The following is a description of a gene set: from publication Yevshin I, Sharipov R, Kolmykov S, Kondrakhin Y, Kolpakov F (PMID 30445619) Mouse Gene Set: CTR9_TARGET_GENES studied in species Mus musculus Genes containing one or more binding sites for (Ctr9) in their promoter regions (TSS -1000,+100 bp) as identified by GTRD version 20.06 ChIP-seq harmonization., and this is the list of marker genes: Mfsd11, Gm25296, Rps19, Ewsr1, Necab3, Elf1, Gm11520, Rpl11, Cacnb3, Zfp322a, Ncapd2, Fgfr1op2, Napepld, Sox12, Mir6236, Mcm10, Itga6, Unk, Mir207, Septin2, Gm4890, Smarcd1, 3010003L21Rik, Lrrc24, Lrrc2, Hdac1, Cc2d1a, Wdtc1, AV099323, L1td1, Mrpl12, Ssmem1, Kin (NCBI Gene Id 209375), Srsf11, Ccnb2, Rab10os, Pnrc2, Hax1, mt-Tl2, Prc1, Shisa7, 1700001G11Rik, Mtg1, Taok3, Trex1, Smg7 (SMG7 nonsense mediated mRNA decay factor), Actb, Lactb2, Adipor2, Cdh24, Dbnl, Ubap2, Ftl1, Iqcg, Ash1l, 1110002L01Rik, Gm15441, Actg1, Rps11 (NCBI Gene Id 27207), Trim65, Vgf, Morc3, Stx5a, Tsg101, Oma1, Sppl2a, Btbd9, Gm25855, Mir290a, Ctnna3, Mfsd14a (NCBI Gene Id 15247), Slc17a9, Pnrc1, Gtpbp6, Etfrf1, 2410002F23Rik, Tor1aip2, Rps15, Cyb5r1, Ccdc47, Apc2, Zzef1, Gm10080, Mir7067 (NCBI Gene Id 102465984), Rps18, Vrk3, Mgme1, Cyb5d1, Atf1, Ddias, Ankrd60, Snx14, Tmem38a, Acin1, Ube2q1, Jarid2, mt-Tl1, Rbm4b, Cyb5r3, Otx2, Rgl2, Purb, Serhl, Hsp90ab1, Rnf44, Dnaja1, Commd1, Rpl18, Gm14143, H3c15, Tdrd3, Isca1, Fbxo27, Dvl2, Ubb, Pip4k2b, Kat8 (NCBI Gene Id 76692), Tmco1, H4c3, Rnft1 (ring finger protein, transmembrane 1), 1110038B12Rik, Ankrd2, Rbm4, Timm13, Ctxn1, Dnajb4, Arhgap27, Stmn1, Nxf1, Gm22711, Dpysl5, Srsf10, Nop58, Sgf29, Kank2, Fam227b, Praf2, Klf10 (Kruppel-like transcription factor 10), Rcor2, Dph7, Selenok, Gstcd, Bbs1, Gm38058, Diaph1, Hdlbp, Ccdc97, Mir291a, Mcts2, Phc1, Mir294, Trim41, Lbr, Tgif2 (TGFB-induced factor homeobox 2), Tdg, Slc2a1, 4930519P11Rik, Pkp4, Tmem168, Pdrg1, H2bc21, Ppig, Naa60, Fbxo5, Cdk12, Dph3, Ranbp1, Eci1, Tbc1d17, Ralgps2, Cep95, Gm15564, Mir292b, Nfyb, Naa10, Washc1, Chaserr, Mus81, Hdhd3, Gm16892, Setd5, Zfr2, Luc7l3, Gm12984 (NCBI Gene Id 102632547), Rbm7, Zpbp, Baz2b, Rbpj, Pde4dip, Gm16069, Pnma1, Ttc36, Usp21, Gtpbp10, Fcer1g, Pate2, Ddx42, Rab27a, Wdr62, Snord45c, Oxct1, Kctd15, Mir295, Trmt1, Gm24916, Dppa5a, Npat, Apc, Trip12, Zfp82, Fbxl17, Zfp292, mt-Nd1, Edc4, Mindy1, Gm22748, Fam83e, Plod3, Ube4b, Rabgap1, Gpaa1, H2bc15, Snora57, Orc5, Hnrnpk, Wnk4, Gm16283, Inpp5e (NCBI Gene Id 64436), Snord43, Gm22980, Rtkn2 (rhotekin 2, NCBI Gene Id 631847), Oxnad1, Fgfr3-ps, Rprd2, Rpl10a, Bbs10, 1600020E01Rik, Tstd1, Mmaa, Ppm1f, Sgo1, Efhc1, Gm15270, Ppp1cc, Snhg3, Fdft1, mt-Nd5, Mef2b, Larp4, Pop5 (processing of precursor 5, ribonuclease P/MRP family (S. cerevisiae)), Vps33a, Ndufc2, Rpp21, Eml3, Rhbdl1, Zfp219, H2ac15, Arrdc3, H2ac12 (NCBI Gene Id 319168), Erlin1, Hdac4, Polg2, 0610010K14Rik, Gm26511, Iah1, Znfx1, Maml1, Ccdc88a, Nubp1, Gm13267, Fbxo46, Ldha, Inpp5k, Gramd2a, Sinhcaf, Cdca2, Ptp4a2, Sh3d21, Ccser2, Rpl26, H4c18, Prkag1, Cetn3, Eif1, Cyct, Plpp5, Zbtb45, Gm26202, Leprot, Pacs1, Atf7ip, Tbc1d23, Ppp6r1, Rhof, Trp53inp1, Gm26387, Agfg1, Unc13d, Nudt16l1, Taf1d, Cop1, Map1lc3b, Cul4a, Enah, 1700058P15Rik (RIKEN cDNA 1700058P15 gene), Cfap53, Nras, Tor1a, Fam209 (family with sequence similarity 209), Epn1, Gm15510, Snora24, Usf2, Psmg1, Orai3, Hnrnpm, Snora65, Kif15, Snord55, Ncl, Mbd3, Zfp696, Copg1, H4c9, Capzb, Prps1l3, Zscan22, Ticam1, Kank3, Diablo, Pygo2, Mrpl51, Dcaf8, Rabggtb, Pcna (NCBI Gene Id 18538), Akr1a1, Zfp646, Jade3, Rpl15 (NCBI Gene Id 66480), 1700088E04Rik, Sp3, Asb3, Crebzf, Slc27a3, Pisd, Ino80, Raver1, Kpna2, Tbk1, Erlec1, Mir431, Eif4a2, Josd2, Golga1, Arih1, Gm12758, Impdh2, Cd2ap, Gm12516, Ctnnal1, Ing2, H2bc12, Smg6, Arhgef1, Med22, Cfap251, Topors, Mir290b, Gpx1, Oxct1as, Schip1, Rex1bd, Ipo5, Lrrc28, Zbtb37, Wdr5b, mt-Ts2, Dip2b, Lefty2, Rsad1, 1110019D14Rik, Trim46, Tigd3, Grhpr, Uba2, Bphl, Nucks1, Rpl34, Capn15 (calpain 15), Gm5113, Thoc6, Rubcn, Usp6nl, Rusc1 (NCBI Gene Id 99477), Pgam5, Rnf151, Rhbdd3, Lrif1, Dlc1, Stip1, Mir7655, Mtf2, Cox20, Trim37, Rpl7, Pcyt2, Tssk6, Rps29, Cox7a1, Zglp1, Tmem201, Srcap, Gm25744, Sipa1l1, Ttll4, Dcp2, Kdm4c, Akt1s1, Ash2l, Plpp1, Gm31266, Gm12762, Chd2, Cenph, Zfp518a, Fubp1 (NCBI Gene Id 77392), Usp10, Hdhd2, Klf6, Lpcat3, Rilp, 4632404H12Rik, Ift74, Snhg9, Senp3, Naa35, Eogt, Mat2b, AW209491, Fam193a, Mettl25b, 2200002D01Rik, Ube2w, Rnf4, 1700023H06Rik (RIKEN cDNA 1700023H06 gene), Lasp1, Gm24044, Ncoa4, Nat10, Snora61, Fyttd1, Zfp329, Spag1, Mir101b, Rbm15b, Gm11398, Bola1, Cfap69, Itfg2, Nudt9, Slc38a1, Polr2f, Dtwd2, Prpf4b, Sec61a2, Amigo3, Ccdc59, Hsd17b8, 0610009L18Rik, Bcar3, Cd320, Sanbr, Tti2, Cirbp, Sra1, Elk4, Jade1, Gfpt1, Rpl36a, Ska2, Lck, Atxn2l, Zfp619, Hmmr, Abitram, Lnpep, Tmem270, Cnih4, Lzic, Ovca2, Gm19710, Gm12267, Ppp1r18, Snora64, Tom1, Mir8120, Kctd5, Zfp81, Ppp2r3d, Cox16, Rcc1, Pcnp, Itpr3, Gm12059, Gm21985, Kat7, Mbtps2, Egln2, Atp5f1d, Med17 (mediator complex subunit 17), Zfp653, Soat1, Gm26604, Hsf5, Lypla1, Uckl1os, Gm23246, Tuba1b, Pole4, Ssc4d, Zdhhc20, Rars1, Msh4, Zfp668, Tfg, Ccdc163, H4c8, Rpl5, Tmpo, Cldn7, Gmip, Tob2, 1810030O07Rik, Aftph, Cdkl3, Rab26, Mterf2, Mxd1, Dcdc2b, Gm24452, Wbp2 (WW domain binding protein 2), 4930544D05Rik, Stap2, Mir8092, Mrpl41, Gm23212, Zic5, Tbc1d8, Hnrnpu, Cox18, Ager, Psip1, Slc1a5, Mcm7, 4930481B07Rik (RIKEN cDNA 4930481B07 gene), Yy2, Pcmt1, Slc35c2 (solute carrier family 35, member C2), Ccdc157, Bcas2, Arih2, Dnai7, Rad51, H2af-ps2, Gnb2, Rnpc3, Zfp866, Snx9, Fbxo22, Klf3, Rnf13, H3c2, Spmip11, Arf1, Plppr2, Epha2, Gas5, Atp5f1c, Nit2, Tapbp, Myo10, Gm22680, H2ac20, Plscr3, Ccnd3-ps, Taf6l, Rbm3os, Slc16a3, H2ac14-ps, Snord22, Zfp799, Ap4m1, Sart3, Timmdc1, Slc31a1, Pdcd6, Tmem106a, Ipmk, Mkrn1, Ube2k, Myl6b, Cdk7, Disp2, Arf4, Rmi1, Timm29, Snord45b, Map3k1, Ksr2, Klhl13, Prrt2 (proline-rich transmembrane protein 2), Clta, Rpl3, Mmadhc, Huwe1, Cspp1, Anp32e, Slc12a6, Stx3, Gm17259, E130102H24Rik, Tpd52, Txnip, Snx5, Mcm6, Twf1, Afmid, Arid1a, Itgb1bp1, Snhg5, H1f3, Kat2a (K(lysine) acetyltransferase 2A), Taf11, Trim6 (tripartite motif-containing 6), mt-Th, Baiap2l2, Atp2b1, Rplp0, Gm6069, Gm23201, Mir291b, Lmf2, Stam, Gm23969, Dyrk1b, Mir3071, Mtmr4, Anks3, A230072E10Rik, Lysmd3, Znhit2, Slc25a36, Caprin2, Uap1l1, Dcps, Fam174c, Wwp2, Cort, Wdr81, Grhl2, Mir1949, Gm22455, Reep2, Cmya5, Xpot, Eif4a1, Zfp346, Gm26590, Gm10785, 2700078F05Rik, Lhfpl5, Arhgap35, Isy1, Tbrg1, Ifi30, Gm23946, Ssr2, Snapc3, Zfp229 (zinc finger protein 229), Ppp1r8, Ints12, Snord49a, Prx, Snhg17, Dennd2c, Zfp91 (NCBI Gene Id 67567), Gm4462, Ddah2, Tsc22d1, Tmem230, Mir292, Arsa, Mtfr2, H2ac5-ps, Dusp28 (dual specificity phosphatase 28), H3c8, Prorsd1, Rala, Slc7a7, Acsl3, Pam16, H2bc3, Bag6, Apex1, Tbc1d7, Kctd9, Mir7017, Cds2, Fmc1, Rps23rg1, Epas1, Pcid2, Usp7, N4bp2os, Epm2aip1, Pkmyt1, Jmjd8, Fbxl5, Eef1g, Kcnn2 (potassium intermediate/small conductance calcium-activated channel, subfamily N, member 2), Pggt1b, Cdo1, E4f1, Greb1l, Thoc5, Spty2d1, Pagr1a, Ddx5, Eif4g2, Adhfe1, Kmt2e, Snord87, Eif4a3, Sirt7, Cd2bp2, Srsf5, Otud1, H2bc11, Ptp4a1, Bltp3a, Ypel5, Mmp24os1, Prpf6, Gm23690, Gm10433, Meg3, Zfp788, Ube2n, Gm23301, Golph3l, Psen1, Fam151b, Pms2, Nfkbil1, Gm21182, Snora21, Mir6991, Rmc1, Csrp2, Poldip3, Man2c1, Ppcdc, Gdpd3, Hmgn2, Tex52, Ago3, Gtf2a2, Phtf1, Dnajc11, Vapa, Scrib, Dhx30, Mapkbp1, Zfp367, Pabpn1, Prr3, Ahdc1, Gm57857, Rps15a, Rbm25, Snora73b, Akap5, Snord38a, Znhit1, Akt2, Mirlet7g, Ssh3, Ndufb6, Mfsd10, Arl6ip1, Rab11b, Kbtbd4, Borcs8, Malat1, Caprin1, Zfp687, Rpl21 (ribosomal protein L21), Gabarap, Ints5, Rps8, AF357399, Fut11, Gm11175, Cand1, H2bc6, Gsto2, Gm22357, Srsf2, Gm20544, Gm19325, Tgfbr3l, Ddx41, Vegfb, Ranbp17 (RAN binding protein 17), Pold1, H4c6, Slc8a2, Utp14b, Rogdi, Gnpnat1, 1700096K18Rik, Gm23639, Gm22744, 6030443J06Rik, Spaca6, Spc25, Mettl9, Ggnbp2, Zfp74, 4930592C13Rik, Sigirr, C130036L24Rik, Cops7a, Polr2a, Ddx23, Jpt2, Zfp638, Uspl1, Klhl10, Tcf7, Clhc1, Zfp106, Phf1, Nkiras1, Dap3, Paxip1, Zfp513, Gpr19, 4931406C07Rik, Osbpl1a, Opa1, Mir5119, Dido1, 5031425E22Rik, Rbm47, Ddx19b, Fam83g, Trip4, Gm21992, Gm22489, Shkbp1, Strada, H2ac8, 4921522P10Rik, Rev1, Vamp1, Csnk1g1, Tonsl, Zfp281, Rps27a, Moap1, Upf1, Thg1l, Ddx39a, Sap25, Tmem41a, Uckl1, 9330171B17Rik, Fam131a, Fut8, Brme1, Sumf2, Matr3, Ostm1, Sfpq, Snord52, Snord13, Scaf11, Rad23a, Zmynd8, Tubb5, Katnal2, Tet1, Mtmr10, Atp7a, Blvra, Rps17, Snapc5, Setx, Ints15, Gm14966, Ubc, Cnot8, Arhgap4, Arhgef25, Zfas1, Rnh1, Mir145a, Stpg2, B230369F24Rik, Tex264, Nceh1, Snord15a, Cmtr1, Pdcl, Ift80, Pcnx4 (pecanex homolog 4), Rps2, Kdm4b, Fam98c, Cisd3, Hcfc1r1, Mir6936, Chd8, Gm16208, Gm22879, H2ac13, Pcbp1, Marveld2, Uchl1os, Xkr8, Tmed4, Usp42, Zfp473, 4930578M01Rik, Mir1894, C1qbp, Snora68, Gm16183, Rnf2, Snord17, Cpt1b, Ing4, Coq2, Dapk3, Srebf1, H2bc4, Rsph6a, Rpl9, Ralgds, Aurka, Pcif1, Phf23, Ptprs, Dctn1, Noct, Tut4, Fkbp15, Kansl1, Ganab, Tor1aip1, H2ac6, Mettl25, Gm6939, Odr4, Nt5c3b, Ing1, Rps27l, Rnf32, Ropn1l, Gm9442, Limk2, Elk1, Zbtb6, Il4i1 (NCBI Gene Id 15088), Hnrnpdl, Farp2, Lias, Pigo, Gm26205, Zbtb11, Ndufb10, Snora73a, Klhdc10, Cep192, Smad7, Adat1, Mipol1, Pih1d1, Ndufs3, Rassf3, Snta1, Dusp12, Ppp2r1a, Paip2, D8Ertd738e, Ppp1r16a, Prr7, Eef1a1, Ccne1 (NCBI Gene Id 12447), Tbc1d14, Vcp, Agps, Rragc, Coq8b, Tpm3, Mir3098, Urgcp (NCBI Gene Id 72046), Zfand1, Tpt1 (NCBI Gene Id 22070), Taf1, Micu3, Gm25894, Lhb, Hnrnpa0, H2ac18, Nmnat1, Dhrs11, Gm26725 (predicted gene, 26725), Man2c1os, Amdhd2, Rnf38, Drg2, Ubxn6, Trmt2a, Asb1, Slc25a2, Ppp2r5a, Cnbp, Grin1os, Timm21, Dnajc5, Adgre5, Gbx2, Ttc39d, Snhg12, Cimip2a, Dancr, Tardbp, Tmem81, Pim1, Gm29257, Fance, Spmap1, Iffo1, Mir200a, Spg11, Qki, Rpl13a, Mxi1, Zfp410, Ulk3, Ep400, Rpl6, Akap8, Fam89b, Marchf8, Sbf1, Senp1, Trpm4, Rps14, Klhl35, Usp16, Eloc, Trpm8, 1500002C15Rik, Mycn, Smim30, Rasgrp2, Maz, Ubtf, Nop2, H2az1, Cep295, Efnb2, Slc35d2, Mgat2, Gp5, Ank1, Brpf3, Pom121l2, Hip1, Slc25a5, Flot1, Pafah1b1, Myg1, Epb41l4a, Uba1, H1f2, Gm11335, Arhgef7, Gm10244, Dnajb14, Vps16, Malsu1, Rbm39, Srr, Gm15327, H4c14, Dnajc4, 4930439D14Rik, Slc25a39, Rfxank, Tmem79, Them4, 1110059G10Rik, Prr12, Mvp, Hccs, Snrpe, Lyrm9, 4833445I07Rik, Zc3h10, Adnp, Pcf11, Flot2, Uchl1, Otub1, Exo1 (NCBI Gene Id 70554), Atat1, Snord12, Dkc1 (NCBI Gene Id 56842), Snora26, Lyset, Tdrd12, Swi5 (NCBI Gene Id 98849), Lmln, Anxa3, Clcn4, H3c6, Ptms, Tspoap1 (NCBI Gene Id 207777), Snord58b, Npm3, Pnpla6 (NCBI Gene Id 50767), Map2k2, Ifrd1, Tnfsf13os, Rabl6, Bcl3, Neat1, Gm10382, Gm9887, Vps4a, Rpl30, Sipa1, Gm43403, Osgep, 2410006H16Rik, Rab18, Rpl35a, Gja4, Hspa8, Tmem240, Hagh, Lockd, Nf2 (neurofibromin 2), Mir6347, Cox7c, Gabpb2, Zfp1006, Gm13483, Rian, Gm22193 (NCBI Gene Id 115485679), Wdr46-ps, Mir1224, Entrep3, Zfp146, Kis2, Mir6905, Zfp384, Smim7, Sde2, Smim14, Cog1, Wdfy1, Gm26224, Slc35a2, Ndufaf3, Tbx3os1, Por, Rpl12, Sf1, Smoc1, Snord49b, Tex22, Sfi1, Med28, Trim13, Hmg20b, Ptpn6, Dixdc1, Hnrnpf, Gm15247, Pltp, Tusc2, Son, Rpl7a, Elp1, Cnih2, Mm2pr, Fis1, Zfp143, Mageb3 (NCBI Gene Id 17147), Anln, Donson, 1700067G17Rik, Pomt1, Mrpl44, Gm20324, Apbb2, Tssc4, Rbck1 (RanBP-type and C3HC4-type zinc finger containing 1), Asns, Myl12b, Cfap157, Snhg6, Gm4285, Asxl2, Slc3a2, Yars2 (tyrosyl-tRNA synthetase 2 (mitochondrial)), Fnbp4, Chek1, Zfp672, Mtln (mitoregulin), Cd68, Fdx2, Elmo3, Pfas (phosphoribosylformylglycinamidine synthase (FGAR amidotransferase)), Slc25a22, Sphk2, Pnpla7, Mir3091, Araf, Adipor1, Scfd1, Fbxo4, Zfp202, G2e3, Fads6 (fatty acid desaturase domain family, member 6), Gm13610, mt-Cytb, Fbxo6, 2610020C07Rik, Zfp13, Tmem39a, Pomp, Scamp3, Gm15559, H2ac21, Mir6933, Rnf123, Btf3, Pdcd2, Rpl28, Taok2 (NCBI Gene Id 68669), Vps52, Gm25322, Epb41l4aos, Arhgap21, Nabp1 (NCBI Gene Id 98468), H4c4, Papola, Kxd1, Timm23, Mir674, Park7, Clk2, Camta1, Pink1, Supt16, Rnaseh2a, D030040B21Rik, Map3k12, Lefty1, Gm25939, Nrn1l, Chtop, Ctdspl2, Pld3, Gdi1, Ccdc138, Cdc20, Kmt5a, Mpv17 (NCBI Gene Id 17527), Syne4, Gm20604, Irf9, Kcnd1, Azin1, Cic, Mir1668, Ctsk (cathepsin K), Ap3m1, 4930539J05Rik, Rnf141, Mast1, Ddit4, 1700113A16Rik, 1700019D03Rik, Smg5, Aldoc, Cbl, Gcn1, Degs1, Krtcap3, Mir1893, Bud13, Mfsd2b, Set, Ccar2, Gls, Mterf3, Zfyve1, Alkbh7, Lrsam1, 1810009A15Rik, Acrbp, Ccdc92b, Mir6935, Gm15983, Zbtb20, Prdx5, Sod2, Fam135a, Hmces, Gm23130 (NCBI Gene Id 115487513), Gng13, Dyrk3, Gm12279, Mmachc, Wdr4, Mrps18b, Nabp2, Ing5, Sqstm1, Tpr (NCBI Gene Id 74816), Scg5, Tmem35b, Gskip, Lbhd1, B3gat3, Luc7l, H2ac11, Atp6v1e1, Zbtb22 (zinc finger and BTB domain containing 22), Rps9, Bcl2l12, Polr3gl (polymerase (RNA) III (DNA directed) polypeptide G like), Ccdc62, Cntrl, Nudcd2, Spag8, Platr3, Hsp90aa1, Ing3, Prcp, Usp48, Man2b1, Zfp593os, Ppp3ca, Secisbp2, Chmp2a, Unc119, Gm15246, Zfp597, Rpl27, Psmd8, Stc2, Gm5577, Mrm1, Snora16a, Pdhb, Thap1, Gm15421, Hmga1, Snord104, Naa38, Pdf, Pcbp2 (NCBI Gene Id 18521), Snord118, Brd8dc, Zc3h4 (zinc finger CCCH-type containing 4), Gm15725, L3mbtl2, Gm24610, Ppm1a, Tomm40, Rpl22 (NCBI Gene Id 67183), C230037L18Rik, Gramd1a, 1700039M10Rik, Frmd8os, Tarm1, Bclaf3, Gas2, Rps10, Ccne2, Snora44, Septin9, Tyro3, Prdx1, Ube2d3, Dnmt1, D2hgdh, Cul7, Far1, Pwp2, 9430015G10Rik, Irf2bpl, Ap1m1, Atg14, H4c1, Tmem237, C330002G04Rik, Rrp36, Mcm3ap, Xpo1, Hnrnpl, Sbno2, Gm12089, Gnl1, Nutf2 (NCBI Gene Id 68051), Rtn4, Gm1123, Gtf2e2, Gm15420, Nr2c2, Gm26330, Zfp563, Ube2d-ps, Naprt, Mir293 (NCBI Gene Id 100049714), Styx, Rad9b, Gzmm, Birc2, Eef1akmt1, Snord2, Tm6sf2, Hlcs